The following is a description of a gene set: A homeostatic process involved in the maintenance of non-mineral tissue, by preventing mineralization of non-skeletal tissue. studied in species Mus musculus Mouse Gene Set: GOBP_INHIBITION_OF_NON_SKELETAL_TISSUE_MINERALIZATION, and this is the list of marker genes: Ada, Alpl, Atf1, Adora2a, Adora1, Ank, Abcc6, Enpp1, Nt5e, Creb1